The following is a description of a gene set: The regulated production of heat in response to short term environmental changes, such as stress, diet or reduced temperature. Mouse Gene Set: GOBP_ADAPTIVE_THERMOGENESIS species: Mus musculus, and this is the list of marker genes: Ache, Ghrl, Scd1, Rb1, Trpv4, Tle3, Nr1h2, Lpin1, Il4ra, Mcrip2, Oma1, Flcn, Wnt10b, Thra, Lama4, Ddit3, Gatm, Lncbate1, Alpl (NCBI Gene Id 11647), Pwwp2b, G0s2, Ccr2, Ucp1, Acot11, Foxc2, Gnas, Trpv1, Dio2, Clic5, Cav1, Fabp5, Jak2, Lipa, Cpt2, Nrdc, Gadd45g, Nr1d1, Ffar4, Map2k6, Atf4, Trpm8, Acvr2b, Per2, Zbtb7b, Zfp516, Ces1d, Adrb2, Sct, Trpv2, Bola3, Appl2, Bmal1 (basic helix-loop-helix ARNT like 1), Ogt, Nova1, Epas1, Syk, Ybx2, Vegfa, Prlr (prolactin receptor), Arrdc3, Oxt, Slc25a4, Slc25a5, Plac8, Nova2, Letmd1, Cidea, Pctp, Stat6, Hsf1, Cnot3, Sfxn5, Acsl1, Lepr, Slc25a44, Adipor1, Il15, Dbh (dopamine beta hydroxylase), Decr1, Ckb, Ip6k1, Esrrg, Dhrs7b, Aldh1a1, S100b, Phox2b, Adrb1, Dock7, Pemt, Rheb, Ucp3, Il18r1, Bscl2, Prkab1, Rbpj, Irf4, Pparg, Sorl1, Plcl1, Sctr, Il4, Mfap2, Adrb3, Kdm1a (lysine (K)-specific demethylase 1A), Lep, Hoxc10, Ebf2, Mfn2, Pdgfc, Adipoq, Hadh, Cd36, Igf2bp2, Prdm16, Alms1, Elovl3, Pm20d1, Fabp4, Adam17, Adamts5, Stk11, Zfp423, Pth2r, Gpr39, Adipor2, Smarca4, Actn3, Gpr3, Hnrnpu, Apc, Fh1, Prkab2, Il18, Kdm6b, Tfe3, Cebpb, Tlr4, Dync1h1, Igf1r (insulin-like growth factor I receptor), Adissp, Ppargc1b, Ksr2, Sirt6, Acadl, Ehmt1, Grb10, Notch1, Bmp8b, Oxtr, Cmklr1, Ucp2, Tshr, Hdac3, Nr1h3, Lgr4, Ppargc1a, Qki, Elovl6, Gja1, Pgam5, Mc4r, Fgf21, Sln, Id1, Plcl2, Il13, Clstn3, Hcrt, Cxcr4, Npr3, Kdm3a, Lnpep, Adcyap1, Acot13, Abhd6, Lcn2